Given this list of marker genes SURF1, ZNF710, GNB2, PPP2R5A, CRYL1, ZMPSTE24, SCAMP1, GAA, ZZEF1, TP53I13 (NCBI Gene Id 90313), SRI, ADRB2, BMPR2, SLC7A8, DOK3, CXCL16, STMP1, TESK2, CD302, CAT, GMNN, ANTXR2, BRAP, AKT1, CDKN2D, PARP8, HPS4, PIKFYVE, C1QA, IFI27, DPY19L4, ZSWIM8, COMT, KDM3B, TTC14, GNA12, UPF3A, MMD, FBXL4, GOLGB1, PPP3CB, MYLIP, ZMYND15, PPP1R12C, KATNIP (katanin interacting protein), WDR81, TEF, HSDL1, SERHL2, SEPTIN8, KLF6, E2F8 (E2F transcription factor 8), LANCL2, SMPD5, ERLIN1, GLCCI1, UBE3B, PIGP, GSTM3, MBD1, DYNC2LI1, MAGED1, TOB2, CRLF3, GRB2, CBY1, SLC37A1, MAP3K5, ZDHHC7, DBP, TBC1D14, ARRB2, SLC25A45 (solute carrier family 25 member 45), ADCY9, GSTM5, SETD1B, PPARD, TRIT1, EIF1B, BASP1, KDM2B, ZNF627, BST2, VASP, MAP3K8, ERP29, CSNK1E, ADAM17 (ADAM metallopeptidase domain 17), TRAPPC6A, MDP1, CAMP, EP300, TCTA, OLFML3, CMTM7, STARD9, RASA4, STIMATE, PDE8A, PHF14, ZNF251, IFIT1, TOMM7, RAB32, LAMP1, PDSS2, HNRNPL, KIAA1143, SCAMP2, HMOX2, ZXDC, SULF2, CNP, TFAP4, ARL4D, TMEM101, RANBP10, CXCL10, TOP1, RNF135, MGAT4A, NFE2L2, USP21, TCF12, FECH, NCAPG2, DGKZ (NCBI Gene Id 8525), SLC16A6, DHX58, ENC1, INCENP, FAU, NADK, VSIR, SCRIB, CD300A, ABTB1, GLUL, IFI27L2, CDK1, NDST2, MOB3A (NCBI Gene Id 126308), CAPZA2, CACUL1, SELENOH, PKIB, ZFAND4, APOBEC3B (apolipoprotein B mRNA editing enzyme catalytic subunit 3B), DDX60, ZNF445 (NCBI Gene Id 7721), KIFAP3, LAMTOR4, ZNF22, UBA7 (ubiquitin like modifier activating enzyme 7), SFXN5, RPL27A, TMEM68, RAB11FIP3, NOP53, PLEC, OGFRL1, ALDH2, C12orf57, FAM174A, WDR6, NCBP2AS2, CNOT4, TFPT, IL16, GRK3, VAMP3, FNBP1L, LSP1, LRRC45, ELF2, C8orf58, CALHM6 (calcium homeostasis modulator family member 6), CUX1, CTSH, TPST2, ZCCHC8, PKIG, ARHGAP45, GRN, GDPD1, WDFY4, RBM43, LZTR1, FXYD5, LSM10, IDH2, GPN3, SMOX, LTO1, RYBP, RNPEPL1, ZC3H4, MTMR14, NCOA3, PWWP2B (PWWP domain containing 2B), here is a description of the gene set: Human Gene Set: GSE5589_LPS_VS_LPS_AND_IL10_STIM_IL6_KO_MACROPHAGE_180MIN_UP Genes up-regulated in bone marrow-derived macrophages with IL6 knockout and 180 min of stimulation by: LPS versus IL10 and LPS. species: Homo sapiens from publication El Kasmi KC, Holst J, Coffre M, Mielke L, de Pauw A, Lhocine N, Smith AM, Rutschman R, Kaushal D, Shen Y, Suda T, Donnelly RP, Myers MG Jr, Alexander W, Vignali DA, Watowich SS, Ernst M, Hilton DJ, Murray PJ (PMID 17114459) IL-10 or IL-6 stimulation of control 129xC57BL/6 murine bone marrow derived macrophages in the presence of LPS. We used microarrays to detail the global programme of gene expression changes in response to IL-6 or IL-10 stimulation in the presence of lipopolysaccharide. BMDMs were isolated from control, IL-6-/-, and IL-10-/- mice on a 129XBL/6 mixed background mice and differentiated in the presence of CSF-1 for 6-7 days. Cells were scraped and plated in 6 well plates at 2x10e6/well. Cells were washed with complete DMEM and rested for 1-2 hr before stimulation with combinations of IL-10 (10 ng/ml), IL-6 (2 ng/ml) or LPS (100 ng/ml) for 45 min or 180 mins. Complete biological replicates were performed.